The following is a description of a gene set: Mouse Gene Set: CUI_CDC2_CD30L_RESPONSE_DN studied in species Mus musculus from publication Cui A, Huang T, Li S, Ma A, Pérez JL, Sander C, Keskin DB, Wu CJ, Fraenkel E, Hacohen N (PMID 38057668) Cytokines mediate cell-cell communication in the immune system and represent important therapeutic targets. A myriad of studies have highlighted their central role in immune function, yet we lack a global view of the cellular responses of each immune cell type to each cytokine. To address this gap, the authors created the Immune Dictionary, a compendium of single-cell transcriptomic profiles of more than 17 immune cell types in response to each of 86 cytokines (>1,400 cytokine-cell type combinations) in mouse lymph nodes in vivo. A cytokine-centric view of the dictionary revealed that most cytokines induce highly cell-type-specific responses. For example, the inflammatory cytokine interleukin-1β induces distinct gene programmes in almost every cell type. A cell-type-centric view of the dictionary identified more than 66 cytokine-driven cellular polarization states across immune cell types, including previously uncharacterized states such as an interleukin-18-induced polyfunctional natural killer cell state. Genes negatively differentially expressed in cell type: cDC2 (conventional dendritic cell type 2) upon treatment with cytokine: CD30L in mouse lymph nodes in vivo., and this is the list of marker genes: Zfp36l1, Ier5, Neat1, Zfp36, Egr1, Srpk1, Fosb, Pmaip1, Il1b, Ptgs2, Coq10b, Atf3, Btg2, Dusp1, Klf2, Junb, Fos